Given this list of marker genes FIGN, USP49, PTER, YTHDF3, UBE2A, HTR7, STAG2, PAX8, TUT4, B4GALT5, UTY, LUC7L2, LCOR, RAB21, MBNL1, RANBP9, IRF2, EP300, BCORP1, KDM6A, ZNF800, PGM2L1, FLRT2, EIF4G2, SLC6A15, BDNF, CSTF3, TPPP, ARGLU1, ZNF207, RBFOX1 (RNA binding fox-1 homolog 1), DYRK1A, BRINP3, ATP11C, HERC6, ZNF423, FGF12, CPEB4, CDIN1 (NCBI Gene Id 84529), SLC25A31, PDE6D, RC3H1, ADAMTS19, HMGB3, NAMPT, SNAP25, KLHL2, FAM167A, GID4, CNOT4, NRXN1, KCNK10, ADAT2, BMI1, LTN1, NR4A3, PCDH19 (NCBI Gene Id 89774), TRPS1, PHTF2, CUL5, KLHL4, BCOR, HERC4, HIVEP2, PROK2, APP (NCBI Gene Id 351), RBM26, CALML4, SAMTOR, BIRC6, LARP4, KITLG, C6orf141, ITGAV, APAF1, LRRTM3, MLLT3, BOLA2, LIN28B, LYPLA1, KBTBD2, SNX2, PRKCB, WDR26, TRIM36, MEF2C, UBR3, FNDC3A, PPP1R8, EIF4E, CHMP2B, STYX, ATXN2L, EPB41L1, STC1, IL1RAPL1, SP4, EPC2, ZFPM2, ZBTB20, ARPC5, TBL1XR1 (NCBI Gene Id 81612), here is a description of the gene set: studied in species Homo sapiens Genes having at least one occurence of the motif ATTACAT in their 3' untranslated region. The motif represents putative target (that is, seed match) of human mature miRNA hsa-miR-380-3p (v7.1 miRBase). Human Gene Set: ATTACAT_MIR3803P